The following is a description of a gene set: Mouse Gene Set: GOBP_REGULATION_OF_MACROPHAGE_DERIVED_FOAM_CELL_DIFFERENTIATION species: Mus musculus Any process that modulates the rate, frequency or extent of macrophage derived foam cell differentiation. Macrophage derived foam cell differentiation is the process in which a macrophage acquires the specialized features of a foam cell. A foam cell is a type of cell containing lipids in small vacuoles and typically seen in atherosclerotic lesions, as well as other conditions., and this is the list of marker genes: Hbp1, Lpl, Crp, Adipoq, Itgb3 (integrin beta 3), Nfkbia, Alox8, Apob, Pla2g5, Msr1, Itgav, Tnf, Ppara, Csf1, Agt, Csf2, Mapk9, Pparg, Prkch, Agtr1b, Pla2g3, Il1b, Il18, Abca5, Cd36, Agtr1a, Nfkb1, Abcg1 (NCBI Gene Id 11307)